The following is a description of a gene set: Catalysis of the reaction: acetyl-CoA + histone H3 L-lysine (position 14) = CoA + histone H3 N6-acetyl-L-lysine (position 14). Human Gene Set: GOMF_HISTONE_H3K14_ACETYLTRANSFERASE_ACTIVITY studied in species Homo sapiens, and this is the list of marker genes: KAT6B, KAT6A, JADE1, ING4, BRPF3, JADE2, KAT7, BRD1, GTF3C4, MEAF6